Given this list of marker genes RAP1GDS1, EEF2K, TCAP (titin-cap), TTN, DAPK3, MYH11, here is a description of the gene set: Human Gene Set: GOBP_MYOSIN_FILAMENT_ORGANIZATION A process that is carried out at the cellular level which results in the assembly, arrangement of constituent parts, or disassembly of a filament composed of myosin molecules. studied in species Homo sapiens